Given this list of marker genes Ndufa8, Ndufb10, Trir, Ubl3, Hspa5, Odc1, Hilpda, Ssrp1, Calm3, Selenop, Pabpn1, Selenoh, Tmem256, Laptm5, Ndufb2, Nkg7, Ly6e, H1f2, Fuca1, Selplg, Akr1a1, Park7, Atp5f1e, Tma7, Cst3, Oaz1, Csrnp1, Tspo, Cox5b, Pomp, Uqcc2, Antkmt, Suclg1, H2-Aa, Swi5, Cd3e, Cd28, Cox7c, AW112010, Gsn, Junb, Actb, Jpt1, Fis1, Hcls1, Mlf2, Il2rg, Gng2, Dpm3, Smpdl3a, Tmem176a, Polr2l, Rex1bd, Cd3g, Cnn2, Atox1, Wipf1 (NCBI Gene Id 98855), Gabarapl2, Ccr2, Anxa5, Rnaset2b, Macroh2a1, Micos13, Ppp1r12a, Ctss, Cdkn1a, Arpc5, Brk1, Dap, Scp2, Atp5pd, Tnfrsf1b, Skap1, Cfl1, Cxcr6, Cox6c, Ndufa1, Ppp1r18, Lmna, Lsm5, Gpx3, Mrpl23, Psmb8, Ptprcap, S100a10, Cd7, Gadd45b, Nabp1, Lrrfip1, Ndufa4, Sfn, Lcp1, Ostf1, Sh2d2a, Ciao2a, Hcst (hematopoietic cell signal transducer), F2r (NCBI Gene Id 218465), Pxdc1, Zfp36l1, Tpm3, Vps28, Ndufb11, Micos10, Cox5a, Atp5if1 (NCBI Gene Id 11983), Rpn2, Rac2, Atp5f1c, Reep5, Lsp1, Zap70, Impact, Trmt112, Myl12b, Lgals1, Capns1, Serpinb9, Atf3, Lsm4, Fkbp8, Ndufv3, Nme1, Fyn, Cd37, Cd6 (NCBI Gene Id 12511), Rgs2, Arhgdia, S100a4, Ssr4, Slc25a4, Thy1, Dnajc15, Comt, Hypk, Anapc11, Ywhaz, Cd47, Wdr1, Anxa2, Selenow, Lime1, B4galnt1, Tnfaip8, Psmb2, Ubc, Cst7, Gimap4, Tmem176b, Atp5f1d, Atp2b1, Lmo4, Cd52, Myo1g, Fos, Bola2, Bhlhe40, Flna, Nop10, Sp110, Actr2, Dcn, Stmp1, Cox6a1, Xcl1, Cox6b1, Itgb7, Tapbp, Jun, Taf10, Uqcr11 (NCBI Gene Id 66594), Gem, Fus, Polr2f, Tomm7, Tnfaip3, Pebp1, Ly6a, Cirbp, Mrps21, Gnai2, Ly6c2, Srrm2, S100a6, Emc10, Tecr, Atp5me, Nt5c, Ssu72, Ccnd3 (cyclin D3), Lsm7, Calm2, Krt14, Glipr2 (NCBI Gene Id 97132), Arpc2, Mrpl33, Tle5, Apobec3, Clec2d, Cdk2ap2, Pfdn5, Arhgap31, Itgb1, Rnf187, Ppp1r14b, Ctsb, Lat, Edf1, D8Ertd738e, Romo1, Prdx5, Cenpx, Id2, Pkm, Cox14, Arhgdib, Ech1, Lgals3, Shisa5, Cd82, Myh9, Rheb, Etfb, Hsp90b1, Aldoa, Ahnak, Sptssa, Ppp1ca, Gpsm3, Ifitm2, Gata3, Pcbd2, Arl2bp, Rnh1, Ube2i, Crip1, Cdc42, Ier2, Ndufa12, Hmgb2, Ccnd2, Spn, H2-D1, B2m, Ptprc, Capg, Glrx, Fcer1g, Txnip (NCBI Gene Id 99524), Grcc10 (NCBI Gene Id 80671), Arpc1b, Cd8a, Tpst2, Esyt1, Dbnl, Ccl5 (NCBI Gene Id 20304), Rps27l, Bcl2a1d, Ndufb3, Tln1, Tob2, Psme2, Nherf1, H2az1, Gstp1, Drap1 (NCBI Gene Id 66556), Hnrnpa2b1, Ppib, Cox8a, Ifi27, H2-T23, Cdk4, Pfn1, S100a13, Ifitm3, 1810037I17Rik, Psmb3, Dbi, Icos, Ptpn6, Celf2, Pdcd4, Sla, Ccdc107, Cox7b, Gm2a, Kctd12, Lamp1, Cuta, Sem1, Ccl4, S100a11, Xist, Itgal, Ndufa11 (NCBI Gene Id 69875), Sri, Hsd11b1, Klrk1, Ubl5, Itm2c, Dusp1, Cd8b1, Chmp2a, Efhd2, Cd69, Il18r1, Cd44, Emp3, Gnb2, Itgb2, Uqcrq, Avpi1, Psmb1, Prr13, Gnas, Sub1, Pigp, R3hdm4, Hmgb1, Ikzf3, Plekhj1, Klf6, Ndufa13, Nfkbiz, Serf2, Egr1, Psmb10 (NCBI Gene Id 19171), Sit1, Rnf19b, Sec61g, Crlf2, Nr4a1, Iqgap1, Dok2, Ddx3x, Bloc1s1, Ywhaq, Klrd1, Smim14, D16Ertd472e, BC031181, Fosb, Msn, Vasp, Zfp36l2, Ndufa7, Psma1, Gpr183, Cd48, Tmbim6, Itm2b, Gng10, Sh3bgrl3, Tap2, Fxyd5, Marcksl1, Cdc37, Tyrobp, Neat1, Rgs1, Ctsd, Atp6v0e, Mrps14, Tmem50a, Timp2, Ergic3, Ddx5, Calm1, Tmsb4x, Tram1, Cotl1, Plaat3, Hsd17b8, Tmem134 (NCBI Gene Id 66990), Cox17, Il2rb, Hnrnpm, Psmb9, H2-K1, Pycard, Cox7a2, Ndufc1, Snrpd3, Serinc3, Vars1, Krtcap2, Ssbp4, Scand1, Atp5mf, Capzb, Furin, Arl6ip5, Glipr1, Cyba, Il7r, Nedd8, Cxcr4, Atp5mc1, Apoe, Slc3a2, Ier5, Emd, Clic1, Pdia3, Jund, Tmem258, Rexo2, Ltb, Arpc4, Gnb1, Tomm6, Mt2, Ms4a4b, Uqcrb, Snrpd2, Rps28, Cyc1, Hnrnpd, H2aj, Ptp4a2, Gabarap, Tmem160, Ctla2a, Cmtm7, Ndufa3, Gmfg, Sf3b5, Mrpl52, Evl, Ndufs6, Malat1, Nfkbid, Klf4, Cbx3, Anxa6, Spcs1, Pet100, Myl12a, Sdhb, Ndufb7, Bcl2a1b, Rnaseh2c, Ccdc12 (coiled-coil domain containing 12), Srsf5, Mt1, Tagap, Atp5mg, Pgls, Ndufb8, Dnajc19, Arhgap9, Trappc6a, Psap, Actr3, Elob, Ost4, Adgre5, Ppp1r11, Rbm3, Uqcr10, Cebpb, Taldo1, Bscl2, Serpinb6b, Ddost, Atp5pf, Snhg8 (small nucleolar RNA host gene 8), Sec61b, Atp5mk, Lpxn, Ucp2, Pglyrp1, Ctsw, Btg2, Dusp2 (NCBI Gene Id 13537), Hnrnpa3, Ndufs7, Kdm6b, Gpx1, Lamtor4, Arf4, Spint2, Lbh, Myl6, Anapc13, Sema4a, Snhg15, Ramp1, H3f3b, Bax, Fgl2, Cops9, Vim, Atp6v1f (ATPase, H+ transporting, lysosomal V1 subunit F), Coro1a, Lamtor2, Txn1, Dad1, Anxa11, Tagln2, Bcl2, Zyx, Nr4a2, Nfkbia, Pttg1, Psme1, Tbc1d10c, Vamp8, Pkp3, Sec11c, Ptms, Bsg, Fkbp3, Arf6, here is a description of the gene set: from publication Tabula Muris Consortium (PMID 32669714) species: Mus musculus Mouse Gene Set: TABULA_MURIS_SENIS_MAMMARY_GLAND_T_CELL_AGEING